Given this list of marker genes TUFM, RPS7, TMEM72, TMEM161B-DT, NR2F2-AS1, ATP1B1 (ATPase Na+/K+ transporting subunit beta 1), RPSA, OBSL1, COX7C, PRDX6, ALDH1A1, PRSS8, FLNB, SGIP1, SUCLG1, ITGB5, PRXL2A, GPC3, ATP5IF1, ERICH1, RPL13, RPS19, APLP2, PRKX, DNAJC11, STPG2, COX6C, IVNS1ABP, PPP1R1A, YBX1, RPL10, ATP5F1E, RPS20, HERPUD1, UXS1, CYCS, RPL3, RPS25, RANBP3L, COA3, SCD5, PRDM16, DNASE1, TMT1A, TACSTD2, PPM1L, MGST3, CD24, RPL27A, SLC12A1, S100A10, PLAU, EPCAM, GUK1, RPL8, CLDN10-AS1, NRCAM, GNAI1, RPS13 (ribosomal protein S13), CDH16, PIK3R1, CD81, GPX4, PDXK, PPARGC1A, RPL11, RPL7, ALDOA, SRP14, RPL35A, RPS27, HSPA2, SSR4, FAM171A1, SGK2, SCHLAP1, ACADVL, PFDN5 (NCBI Gene Id 5204), P4HB, RPL21, CLDN10, RPS18, KIFC3, PLPPR1, NDUFS6, ITM2B, COX7A2, ATP5PB, RPL7A, PGK1, UQCRC1 (ubiquinol-cytochrome c reductase core protein 1), TMSB10, CYC1, PKM, PLXNB1, RPS12, LINC01606, CHCHD2, SLC25A3, SULT1C2, FTH1, GOLM1, RPS28, MST1L, EIF4G2, AIF1L, PLCB1, RPS9, CCDC148, ACSL1, ITM2C, CIRBP, TMBIM6, DEFB1, PANTR1, KIF12, OCIAD1, UMOD, EEF1A1, PFKL, NDUFB10, TSPAN33, PDHA1, RPL12, VEPH1, MAGED1, TPT1, KNG1, RPL14, KCTD16, THY1, LLGL2, CRIP2, NNT, RPLP1, MFSD4A, RPL31, FGFR3, RPL30, HIBADH, SLC3A1, CHCHD10, FAM13A, CST3, SELENOW, MPC2, PKP4, ATP5MC2, ATP5ME, KCNQ1, TMEM59, REEP5, ATP5MC3, PTPN4, PCDH9, PDE1A, CPEB3, ATP5F1B, ATP1A1, UQCR10, RPL18 (NCBI Gene Id 6141), ATP6V0B, USP24, TRIM2, SFRP1, RPS21, RPLP2, EPS8L2, NDUFB9, BEX3, CBR1, CADM1, PSAP, NDUFV1, PTGER3, EIF3K, ENO1, TMEM37, RHOBTB3, NDUFA5, IMPA2, MDH1, TPI1, SLC22A2 (solute carrier family 22 member 2), RPLP0, HPN, DNAJC19, CD59, RPL19, GNAS, RPS17, PTTG1IP, RPS5, CD63, SLC25A4, COX5A, SCNN1A, BAG1, ZHX3, MYO3B, PPIB, HIP1 (huntingtin interacting protein 1), ACAT1, RPL5, APP, COX5B, WLS, HSBP1, B2M, RPS8, NELL1 (NCBI Gene Id 4745), USP2 (NCBI Gene Id 9099), OXR1, TACC1, SORL1, FREM1, MYL6, NDUFB2, RAP1GAP, ESRRG, RPL23, RPS6, RPS23, ACACB, NDUFA4, PEBP1, HADHB, RPL37, BACE2, IDH2 (NCBI Gene Id 3418), NTRK2, UQCRB, CLCNKA, DZIP1, HLA-A, SORT1, ATP5MC1, RPS3A, EFHD1, CPVL, CPEB4, SDC1, MGAT5, GAPDH, RPL6, COX6B1, SARAF, RPL15, HSPA8 (heat shock protein family A (Hsp70) member 8), KIDINS220, SCP2, SERPINA5, SMS, DDX17, RPL41, NACA, UQCRH, UQCRFS1, LMO7, RPL24, UQCRC2, ANK2, HADHA, TBC1D4, RPS3, SDC4, RPS14, CUTA, KCNJ1, FOXP2, SIM2, EEF1D, CNP, PRDX5, ATP5F1A, KCTD1, PLEKHH2 (NCBI Gene Id 130271), CPT1A, NPC2, HS6ST2, CGNL1, PRDM16-DT, NARS1, EEF2, AFG3L2, CLCNKB (chloride voltage-gated channel Kb), RPL27, CA12, VAV3, EPHX2, COX4I1, FAU, OSBPL3, RPS16, NDUFS1, DENND1B, MTATP6P1, GPC5, MPC1, RPL32 (NCBI Gene Id 6161), PRDX3, GSTM3, ACSS3, COBL, COX7B, ATP5MG, RPL4, GOT1, SNHG29, EID1, ANXA11, RPL34, LDHB, GHITM, S100A6, CLCN5, EDF1, RPS11, ESRRB, COL18A1, SDHA, CKB, CAPN2, UBA52, UQCRQ, WNK4, SERF2, KIAA1217, NDUFA1, SELENBP1, PTPN3, AK3, UBB, EGF, CYFIP2, SLC25A5, UGT8, RNF150, ATP5PF, RPL9, TSPAN8, RPL10A, RARRES2, ACSS1, RPS4X, SLC4A7, RPS24, RACK1, RPS15, CNDP2, ARHGAP24, CXCL14, BICDL1, RPS29, RPL13A, GAS6, PLCL1 (NCBI Gene Id 5334), RPS27A, CACNA2D3, NUDT4, IMMT (NCBI Gene Id 10989), ATP5F1C, RPL37A, MAL, SLC16A7, SRSF5, OXCT1, STXBP4 (syntaxin binding protein 4), CAT (NCBI Gene Id 847), PPIA, SLC9A3-OT1, FMN1, CYS1, MRFAP1, FKBP2, STK32B, RPL35, ATP5PD, DSTN, CASR, SOD1, here is a description of the gene set: species: Homo sapiens from publication Lake BB, Chen S, Hoshi M, Plongthongkum N, Salamon D, Knoten A, Vijayan A, Venkatesh R, Kim EH, Gao D, Gaut J, Zhang K, Jain S (PMID 31249312) Human Gene Set: LAKE_ADULT_KIDNEY_C12_THICK_ASCENDING_LIMB